Given this list of marker genes ETNK1, SLC2A3, FST, BCAT1, PNKD (NCBI Gene Id 87830), IHH, PIP5K1B, P4HA2, ANKH, PLET1, CTPS1, TFRC, PTK2B, HOPX, PDK3, USP14, ALPL, DNAJC3, GGCT, MTHFD2, PTGS1, FZD1 (frizzled class receptor 1), SLCO3A1, FKBP5 (NCBI Gene Id 2289), LMO7 (NCBI Gene Id 4008), HK2, PDZK1IP1, MYD88, WDR43, NOCT, SRSF1, CAPRIN2, HSPH1, WNT11, MAT2A, MYC, CKMT1B, ZBTB16, HOXA11, TGFBR3, ATP5F1C, BMP2K, NFIL3, RHOB, CCNG1, STX18, GATA2, CYP26A1, ID1, SGK1, here is a description of the gene set: Human infertility and recurrent pregnancy loss caused by implantation defects are poorly understood. Hoxa-10-deficient female mice have severe infertility and recurrent pregnancy loss due to defective uterine implantation. Gene expression profiling experiments reveal that Hoxa-10 is an important regulator of two critical events in implantation: stromal cell proliferation and local immunosuppression. At the time of implantation, Hoxa-10 mediates the progesterone-stimulated proliferation of uterine stromal cells. Hoxa-10 mutants express a stromal cell proliferation defect that is accompanied by quantitative or spatial alterations in the expression of two cyclin-dependent kinase inhibitor genes, p57 and p15. Hoxa-10 deficiency also leads to a severe local immunological disturbance, characterized by a polyclonal proliferation of T cells, that occurs in place of the normal progesterone-mediated immunosuppression in the periimplantation uterus. Genes co-regulated in uterus during a time course response to progesterone: SOM cluster 8. studied in species Mus musculus Human Gene Set: YAO_TEMPORAL_RESPONSE_TO_PROGESTERONE_CLUSTER_8 from publication Yao MW, Lim H, Schust DJ, Choe SE, Farago A, Ding Y, Michaud S, Church GM, Maas RL (PMID 12554760)